Given this list of marker genes PPP3CA, PPM1F, PPM1A, PPP3CC, PPP3CB, here is a description of the gene set: Human Gene Set: GOMF_CALMODULIN_DEPENDENT_PROTEIN_PHOSPHATASE_ACTIVITY Catalysis of the reaction: protein serine/threonine phosphate + H2O = protein serine/threonine + phosphate, dependent on the presence of calcium-bound calmodulin. species: Homo sapiens